Given this list of marker genes TMEM120B, CYB561D1 (NCBI Gene Id 284613), NUMA1, RITA1, MICAL3, here is a description of the gene set: Human Gene Set: MIR6746_5P studied in species Homo sapiens from publication Chen Y, Wang X (PMID 31504780) Genes predicted to be targets of miRBase v22 microRNA hsa-miR-6746-5p in miRDB v6.0 with MirTarget v4 prediction scores > 80 (high confidence targets).